The following is a description of a gene set: Abnormal second toe morphology Human Gene Set: HP_ABNORMAL_SECOND_TOE_MORPHOLOGY An anomaly of the second toe. species: Homo sapiens, and this is the list of marker genes: HNRNPR, KCNN3, CHSY1, SMARCA2, MAP3K20, BMP2, CEP295, ATP6V1B2, BMPR1B, PIGL, TBC1D24, IPO8, BCOR, TBC1D2B, GDF5